Given this list of marker genes Taf6l, Sf3b3, Taf10, Trrap, Kat14, Kat5, Kansl2, Taf12, Map3k7, Mbip, Tada2b, Taf2, Eny2, Crebbp, Kat6b, Ogt, Brpf1, Phf20l1, Ing4, Phf20, Vps72, Taf5l, Yeats4, Atxn7, Kat8, Pole3, Wdr5, Msl3l2, Actbl2, Pole4, Jade3, Yeats2, Actg1, Jade2, Supt20, Atxn7l3, Taf6, Tada3, Taf9, Epc2, Atf2, Kat2b, Tada2a, Taf7, Acte1, Ep300, Epc1, Brd8dc, Sf3b5, Morf4l1, Ruvbl1, Kat6a, Supt3, Brpf3, Ing3, Kat7, Actl6b, Msl1, Dmap1, Kat2a, Kansl1l, Msl3, Tada1, Brd8, Morf4l2, Actl6a, Mbtd1 (NCBI Gene Id 217110), Taf4, Ruvbl2, Hcfc1, Kansl1, Taf9b, Ep400, Actb, Mrgbp, Meaf6, Supt7l, Kansl3, Zzz3, Ing5, Sgf29, Brd1, Usp22 (NCBI Gene Id 216825), Dr1, Jade1, Taf5, Mcrs1, Msl2, here is a description of the gene set: A protein complex that possesses histone acetyltransferase activity. species: Mus musculus Mouse Gene Set: GOCC_HISTONE_ACETYLTRANSFERASE_COMPLEX